The following is a description of a gene set: studied in species Mus musculus Any process that increases the frequency, rate or extent of the directed movement of sodium ions (Na+) into, out of or within a cell, or between cells, by means of some agent such as a transporter or pore. Mouse Gene Set: GOBP_POSITIVE_REGULATION_OF_SODIUM_ION_TRANSPORT, and this is the list of marker genes: Dmd, Mllt6, Akt1, Scn5a, Adrb2, Ahcyl1, Ikbkb, Cxcl1, Fxyd1 (FXYD domain-containing ion transport regulator 1), Arf1, Ank3, Fxyd2, Drd4, Atp1b3, Scn4b, Gnas, Fxyd6, Cnksr3, Fxyd3, Sgk1, Slc9a1 (NCBI Gene Id 20544), Prss8, Scn3b (NCBI Gene Id 71632), Tescl (NCBI Gene Id 69301), Scn1b, Nkx2-5, Scn2b, Chp1, Akt3, Gpd1l, Cntn1, Fgf13 (fibroblast growth factor 13), Fxyd5, Akt2, Tesc, Fxyd7, Fgf14, Plcb1, Wnk3, Nos1, Atp1b1, Wnk2, Atp1b2, Fgf12, Nedd4l, Fxyd4